Given this list of marker genes MRPL3, MMAA, PNPLA8, HMGCL, ATP5F1D, IVD, here is a description of the gene set: Human Gene Set: HP_ABNORMAL_SERUM_ANION_GAP studied in species Homo sapiens Any deviation from the normal value of the serum anion gap, which is calculated from the electrolytes measured in the chemical laboratory, is defined as the sum of serum chloride and bicarbonate concentrations subtracted from the serum sodium concentration. Abnormal serum anion gap